The following is a description of a gene set: The absolute number of B cells in the blood, per microlitre is below the lower limit of normal of the reference range for the appropriate sex and age-group. species: Homo sapiens Decreased total B cell count Human Gene Set: HP_DECREASED_TOTAL_B_CELL_COUNT, and this is the list of marker genes: ADA, CD79B, IKZF1, RFX5, LRBA, POLD1, KNSTRN, PIK3R1, RAG1, NFKB2, PTPRC, ATP11A, DOCK8, TLR8, TRNT1, FCHO1, STAT1, ARHGEF1, MYD88, PSMB10, B2M, TCF3, PTEN, NHEJ1, PRIM1, IL2RA, DCLRE1B, ALG12, ICOS (NCBI Gene Id 29851), PRKDC (NCBI Gene Id 5591), GFI1, GATA2, POMP, ZBTB24, PIK3CD, IKZF3, FNIP1, MCM10, JAK3, WDR1, NBN, SYK, RAC2, UNC119, MAP3K14, IKBKG (inhibitor of nuclear factor kappa B kinase regulatory subunit gamma), RIPK1, SASH3, IGHM (NCBI Gene Id 3507), REL, IVNS1ABP, MYSM1, BTK, RAG2, DCLRE1C